The following is a description of a gene set: Mouse Gene Set: GOBP_INORGANIC_ANION_TRANSMEMBRANE_TRANSPORT species: Mus musculus The process in which an inorganic anion is transported across a membrane., and this is the list of marker genes: Slc6a1, Slc25a10, Slc25a3, Ano10, Gabra6, Ano3, Slc37a2, Clcn5, Slc1a4 (solute carrier family 1 (glutamate/neutral amino acid transporter), member 4), Ano8, Clcnkb, Slc26a9, Racgap1, Clcn7, Nmur2, Slc26a1, Slc26a8, Ano9, Ttyh2, Casr, Ttyh1, Gabrd, Glra1, Gabrq, Clca3a1, Clic4, Slc6a2, Slc20a2, Slc5a8, Cldn4, Pcyox1, Fxyd1, Apol11a, Cldn17, Slc13a1 (solute carrier family 13 (sodium/sulfate symporters), member 1), Slc5a5 (solute carrier family 5 (sodium iodide symporter), member 5), Gabra3, Slc12a6, Gabrb3, Clcn3, Xpr1, Slc26a11, Gabrg2, Glrb, Slc1a1, Gabrr1, Kcnk1, Vdr, Ano2, Clca4a, Slc37a4, Clcn4, Gabrr3 (NCBI Gene Id 328699), Slc12a3, Slc17a1, Gabre, Slc4a2, Slc26a5, Slc37a1, Bsnd, Ano4, Clcn1, Ank, Ano7 (anoctamin 7), Slc26a10, Glra2, Glra4, Gabrr2, Ttyh3, Gabra5 (NCBI Gene Id 319559), Oca2, Clcc1, Mfsd8, Pacc1, Kcnk2, Slc25a27, Slc26a7, Chrm5, Slc4a8, Slc20a1, Slc12a8, Glra3, Gabrg1, Gabrb1, Slc4a9, Best3, Slc34a1, Clic3, Clic1, Cftr, Clcn6, Tmc4, Slc1a7, Slc17a6, Gabrp, Clcn2, Slc12a9, Slc4a1, Best1, Slc12a4, Slc25a14, Best2, Gabra1, Slc26a6, Slc26a3, Ano1, Slc1a3, Gabra4, Slc26a2, Slc17a8, Gabrg3, Slc4a11, Ucp2, Ano5, Ano6, Clic5, Gabra2, Aqp6, Slc12a2, Lrrc8a, Slc26a4, Slc12a5, Slc12a7 (NCBI Gene Id 52539), Clca2, Slc4a3, Mtor, Slc17a7, Clic6, Slc5a6, Slc12a1, Gabrb2, Clca1, Clcnka